The following is a description of a gene set: species: Homo sapiens The aggregation and bonding together of a set of components to form a focal adhesion, a complex of intracellular signaling and structural proteins that provides a structural link between the internal actin cytoskeleton and the ECM, and also function as a locus of signal transduction activity. Human Gene Set: GOBP_FOCAL_ADHESION_ASSEMBLY, and this is the list of marker genes: NRP1, MAP4K4, ARHGEF7, SDC4, CFL1, THBS1 (thrombospondin 1), TEK (TEK receptor tyrosine kinase), PEAK1, DLC1, PTPRA, ACTN1 (actinin alpha 1), S100A10, COL16A1, SRC, APOD, GREM1, ROCK1, VCL, FAM107A, MACF1, AJUBA, ACTG1, THY1, SLK, SFRP1, DUSP3, DMTN, CTTN, EFNA5, DUSP22, RHOA, ROCK2, ACVRL1, PTEN, ITGB1BP1, LDB1, EPHA3, ACTN2, CLASP2, TSC1, SORBS1, DAPK3, ARHGAP6, ITGA2, TESK2, CAMSAP3, PTK2, BCR, PTPRK, MMP14, WDPCP, PTPRJ, ACTN3, THSD1 (thrombospondin type 1 domain containing 1), CLASP1, MYOC, HRG, TRIP6, EPB41L5, PPM1F, SMAD3, GPM6B, LIMCH1, BCL2, CDH11, TAOK2, RHOD, VEGFA, PIP5K1A, FERMT2, LIMS1, KDR, WHAMM, CORO2B, RCC2, TLN1, SLC9A1 (solute carrier family 9 member A1), RAC1, WNT4, CORO1C, STON1, ABL1, PHLDB2, POLDIP2